Given this list of marker genes Mfn2, Mul1, Prkn, Huwe1 (NCBI Gene Id 97602), Timm23, Hk2, Vdac1, Vps13c, Hdac6 (histone deacetylase 6), Htra2, Smurf1, Optn, Atp5if1, Pink1, Gba1, Cdc37, Tomm7, here is a description of the gene set: studied in species Mus musculus The selective autophagy process in which a mitochondrion is degraded by macroautophagy in a process initiated by mitochondrial depolarization (mtDepo) followed by Parkin binding, and ubiquitination of outer membrane proteins, to remove potentially harm-inducing dysfunctional/damaged mitochondria. Mouse Gene Set: GOBP_TYPE_2_MITOPHAGY